Given this list of marker genes CMTM6, ENSG00000293855, LINC02033, XIRP1, DYNC1LI1, PLCD1, RNU6-1227P, PDCD6IP-DT, TRIM71, KRT8P18, UBE2FP1, RNU6-243P, HHATL-AS1, CMTM7, MIR548AY, RPL29P11, NIFKP7, EIF1B-AS1, CCK, SNORA62, CNOT10, RPL30P4, RN7SKP227, ENSG00000301630, MYD88, MOBP, ENSG00000308516, CSRNP1, FBXL2, ZNF619, VIPR1-AS1, CCR4, TTC21A, ACAA1, OXSR1, PDCD6IP, CTNNB1, SCN5A, SDAD1P3, WDR48, HHATL, MIR6822 (NCBI Gene Id 102466743), ENSG00000201701, NKTR, CCDC13, RPL21P40, ENSG00000287620, ACKR2, CENPPP1, SCN11A, KLHL40, RN7SL411P, RPL18AP7, DLEC1, VILL, RNA5SP128, COX6CP10, CCDC13-AS1, EIF4BP4, PPP2R2DP1, GEMIN2P2, ADAD1P1, ENSG00000231873, APRG1, SLC25A38, CRTAP, RPL36AP17, KRT18P15 (keratin 18 pseudogene 15), VIPR1, SNRK, GOLGA4, POLE4P1, ACVR2B, RPS16P4, SLC22A13, SNRK-AS1, EPM2AIP1, GASK1A, SMIM11P2, RPL23AP43, RPL14, ENSG00000202517, MRPS31P1, HNRNPA1P22, TRAK1, KRBOX1-AS1, ZNF662, TPMTP2, SUMO2P10, ARPP21-AS1, STAC, DDTP1, ZNF620, NBPF21P, RNA5SP129, POMGNT2, SCN10A, ENSG00000295859, CDC42P7, GLB1, TRANK1, SNORA6, FECHP1, RN7SKP58, GOLGA4-AS1 (GOLGA4 antisense RNA 1), SS18L2, RNU5B-2P, ARPP21 (cAMP regulated phosphoprotein 21), LINC01811, CBX3P10, PRADC1P1, UBP1, RN7SL296P, ULK4, RNU6ATAC4P, ENSG00000287629, TMPPE, RPL18AP9, RNU7-110P, RNU6-1301P, RPL21P137, PGAM1P3, CYP8B1, MIR26A1, ACVR2B-AS1, SALL4P6 (NCBI Gene Id 391530), ITGA9, GORASP1 (golgi reassembly stacking protein 1, NCBI Gene Id 64689), RNU4-56P, ENSG00000227245, RPS27P4, KRBOX1, CTDSPL, CNOT10-AS1, RN7SL517P, HNRNPA1P21, RPL5P10, CCDC13-AS2, DSTNP4, EXOG, RFC3P1, RPL36P20, MYRIP, EEF1GP3, LYZL4, ENTPD3, HMGN2P24, SEC13P1, DCLK3, UBE2D3P2, MLH1, CCR8, SUSD5 (sushi domain containing 5), IGBP1P3, EIF1B, RN7SL567P, CMTM8, ATP6V0E1P2, OSBPL10, ZBTB47, GPD1L, SLC22A14, HSPD1P6, RPSA, DLEC1P1, RPL35AP8, ITGA9-AS1, SUGT1P2, HIGD1A, RPL31P18, MIR128-2, CLASP2, SEC22C, NDUFAF4P3, RNU6-235P, RPL21P135, LRRFIP2, TCEA1P2, EEF1A1P24, ZBTB47-AS1, RPSAP11, RPL7AP83, XYLB, CX3CR1, ENSG00000306288, RNU7-73P, NFU1P1, RNU4-78P, ZNF621, here is a description of the gene set: species: Homo sapiens Human Gene Set: chr3p22